Given this list of marker genes HEXA, CYP1B1, TBX1, ADA2, METTL27, GTF2I, ABCC6, MLXIPL, MT-ND4L, ABCG5, F12, HOXA1, COL4A1, ASAH1, HBB, YME1L1, HEXB, SMPD1, ESAM, MT-ND5, TMEM270, NF1, TULP1, NDE1, COMT, SEC24C, GALC, MT-ATP6, NCF1, LDLRAP1, MT-ND2, MT-ND4, RPGRIP1, GLB1, EFEMP1, ELN, BAZ1B, GM2A, STX1A, NDP, SELENOI, PTDSS1, VPS37D, PCSK9, BUD23, NEU1, MYOC, UFD1, ARVCF, JMJD1C, IGFBP7, CLIP2, LRP5, TBL2, FKBP6, GP1BB, LIMK1, GTF2IRD1, ENPP1, POLR3A, MT-ND1, NEK1, HIRA, MT-CO3, APOB, ANTXR1, DNAJC30, EIF4H, FZD4, CTSA, RFC2, MT-CYB, DARS1, PSAP, ABCG8, RREB1, LMX1B, MT-ND6, PRPF3 (NCBI Gene Id 9129), GTF2IRD2, FUCA1, BEST1, LDLR (NCBI Gene Id 3949), here is a description of the gene set: studied in species Homo sapiens Abnormal head blood vessel morphology Human Gene Set: HP_ABNORMAL_HEAD_BLOOD_VESSEL_MORPHOLOGY An abnormality of a blood vessel of the head, including branches of the arterial and venous systems of the head.